The following is a description of a gene set: Scars that form a depression compared to the level of the surrounding skin because of damage to the collagen, fat or other tissues below the skin. studied in species Homo sapiens Atrophic scars Human Gene Set: HP_ATROPHIC_SCARS, and this is the list of marker genes: COL6A3, ADA2, COL1A1, ITGB4, CTSC (NCBI Gene Id 50958), AEBP1, LAMB3, LRP1 (LDL receptor related protein 1), FKBP14, COL1A2, ADAMTS2, THBS2, COL5A1, LAMA3, C1R, COL6A2, C1S, SMAD3, LAMC2, COL6A1, CHST14, MMP1, B4GALT7, PLOD1, DSE, COL3A1, TNXB, KRT5, PLEC (plectin), SLC39A13, COL7A1, COL5A2, DST (dystonin), KRT14, COL12A1, B3GALT6, COL17A1, CARMIL2